The following is a description of a gene set: species: Homo sapiens In this study we compared the effects of IL-2, IL-15, and IL-21 on the gene expression, activation of cell signaling pathways, and functional properties of cells derived from the CD4+ cutaneous T-cell lymphoma (CTCL). Whereas both IL-2 and IL-15 that signal through receptors that share the common gamma chain and the beta chain modulated the expression of >genes, IL-21 that signals via the receptor also containing gamma chain up-regulated <genes. All three cytokines induced tyrosine phosphorylation of Jak1 and Jak3. However, only IL-2 and IL-15 strongly activated STAT5, PI3K/Akt, and MEK/ERK signaling pathways. In contrast, IL-21 selectively activated STAT3. Whereas all three cytokines protected CTCL cells from apoptosis, only IL-2 and IL-15 promoted their proliferation. The effects of the cytokine stimulation were Jak3- and Jak1-kinase dependent. These findings document the vastly different impact of IL-2 and IL-15 vs. IL-21 on malignant CD4+ T cells. They also suggest two novel therapeutic approaches to CTCL and, possibly, other CD4+ T cell lymphomas: inhibition of the Jak1/Jak3 kinase complex and, given the known strong immunostimulatory properties of IL-21 on CD8+ T, NK, and B cells, application of this cytokine to boost an immune response against malignant CD4+ T cells. Genes up-regulated in Sez-2 cells (T cell lymphoma): untreated versus IL2. Human Gene Set: GSE8685_IL2_STARVED_VS_IL2_ACT_IL2_STARVED_CD4_TCELL_UP from publication Marzec M, Halasa K, Kasprzycka M, Wysocka M, Liu X, Tobias JW, Baldwin D, Zhang Q, Odum N, Rook AH, Wasik MA (PMID 18281483), and this is the list of marker genes: ENSG00000286190, IPO4, CCDC82, HSH2D (NCBI Gene Id 84941), SERPINB9, SMPDL3A, RCBTB1, SH3GLB2, TTLL3, SFSWAP, RRP1 (ribosomal RNA processing 1), AZI2, NRIP1 (nuclear receptor interacting protein 1), ACBD4, LY9 (NCBI Gene Id 95630), F2R, TPRG1L, BTD, DALRD3, TNRC6A, KCNN4, RTN1, S100A13, ZBTB49, KMT5B (NCBI Gene Id 54794), ZNF7 (zinc finger protein 7), AAK1, IL2RA, ISG20, ARMC3, BICDL1, ZNF653, METTL17, PPP3CC, RRM2B, PPIL2, DAPK3, SPINDOC, COMMD3, CYTH3, THADA, MED10, CLEC4M, GAB3, NFKBIB, IL21, HPCAL1, BTBD7, NR1H2, COPS6, SLAIN1, CANT1 (calcium activated nucleotidase 1), TUSC2, DEF6, NUP210, ESCO1, NCK1, DLG1, TBC1D17, PI4KA, INPP5K, IL4, RAP2B, CERS4, ATP6V1H, WASHC3, IL17RA (interleukin 17 receptor A), ARHGAP30, MPPE1, SMAP2, MPZL3, ANO10, CREB3, SLC35B3, MIS12, GDI1, PEF1, ACSBG1, SMPD2, ASB3, MEA1, MAP4K1, BABAM1, NAPRT, FAM210B, RNF139, HCLS1, LIMK2, NOL12, CHURC1, KCNJ11, TINF2, IRF2, MTSS1, GALE, PLCXD2, MAP3K8, LETM1, TNFRSF4, LMNTD2, PHC3, DNAJC15, RAD9A, MED28, OTUD5, SERINC1, ACTN2, SLC26A11, NR1D2, SNRK (SNF related kinase), NDUFA7, ESYT1, ARID4B, NTAN1, SMURF1, TES, RAB37, DNTT, ALDOC, FNBP4 (formin binding protein 4), WRAP53 (NCBI Gene Id 55135), RASL11B, ARHGEF3, TBCE, FAS, RNPEPL1, IL21R, VPS37B, PEAK1 (NCBI Gene Id 79834), MIA3, MOB2, TMEM245, LDLRAD4, RFXANK, MPND, SH3KBP1, AMPD3, BAX, RAPGEF6, RASGRF2, ANKRD13D, POLR3D, SEPTIN9, TOR4A, VPS13B, PGAP1, NEXMIF, CNOT6L, SSTR3, CCDC88B, ATP9A, TRAF2, LENG9 (NCBI Gene Id 94059), FLII, GLIPR2, EMC9, DOCK8, CD48, HERPUD2, AKT1, TMEM234, EEF1D, TNFAIP8L2, FYCO1, AKAP13, ABCA1, HLA-DRB1, RBM18, KREMEN1 (NCBI Gene Id 83999), PSMD4, MTFMT, GFM2, LLGL1, ADCY6, TAP2, NEK3, POLR2A, JAZF1, ARK2C, XPO6, FBXL8, PYGB, MYO1E, PHYHD1, COA3, SYF2, STX1A, RRP9, DEXI, RBM33, NADSYN1, ADRM1 (ADRM1 26S proteasome ubiquitin receptor), RNF123, PCGF1, RAB20, SSU72, ITIH4, ATRAID, IFI27